Given this list of marker genes SEC23IP, TNRC6C, DTD2, MLPH, SRFBP1, SLC24A2, CNOT4 (NCBI Gene Id 4850), VWA8, EMX2, GMCL1, PIAS2, CDC40, ANO6, ACACB, BACE1, ENOSF1 (NCBI Gene Id 55556), ACKR2, TNPO3, DMRTC1 (NCBI Gene Id 63947), RTP1, ARPC1A, PTPN7, CLN8, C8orf76, KCNB1, DMRTC1B, CCDC24, TBC1D7, HNRNPUL2, NRXN3, GLG1, TMEM170B, PRXL2C, SH3TC2, GALNT13, CD300E, WDHD1, FGF13, PDE11A, DBNDD2, ZNF26, CCDC141, HIPK3, COL19A1, EPO, CLMN, EEF2KMT, CAPRIN1 (cell cycle associated protein 1), HAUS2, TRIM8, SRSF1, MPZL3, ADRB1, ARL17A, MAP2K4, here is a description of the gene set: Genes predicted to be targets of miRBase v22 microRNA hsa-miR-4421 in miRDB v6.0 with MirTarget v4 prediction scores > 80 (high confidence targets). from publication Chen Y, Wang X (PMID 31504780) Human Gene Set: MIR4421 studied in species Homo sapiens